The following is a description of a gene set: studied in species Mus musculus The hydrolysis of a peptide bond or bonds within a protein as part of the chemical reactions and pathways resulting in the breakdown of a protein by individual cells. Mouse Gene Set: GOBP_PROTEOLYSIS_INVOLVED_IN_PROTEIN_CATABOLIC_PROCESS, and this is the list of marker genes: Prickle1, Rnf7 (ring finger protein 7), Agap3, Psma1, Syvn1, Kat5, Ube2l3, Fem1b, Rpl23, Ppp2r5c, Zer1, Snf8, Fbxo31, Rmnd5b, Cnot4, Pramel42, Ubxn6, Fbxo10, Herc2, Klhl35, Tdpoz8, Cdc34, Prkcg, Styx, Ubxn2a, Bbs7, Rchy1, Ubr4, Trem2, Chmp1b, Dnajc3, Rnf217, Zranb1, Nhlrc3, Trim25, Pramel48, Psmb9, Psmc2, Fem1a, Cul2 (cullin 2), Trib3, Kctd13, Kcmf1, Psma4, Mapk9, Pramel21, Smarcc1, Znrf3, Sgta, Efna1, Spsb3, Saysd1 (NCBI Gene Id 74979), Siah1a, Dtx3l, Rnf216, Pcbp2, Gna12, Amfr, Pramel22, Smurf1 (SMAD specific E3 ubiquitin protein ligase 1), Arrdc1, Apoe, Pramel40, Kctd21, Ube2r2, Disc1, Acr, Sec61bl, Gipc1, Uchl3, Hectd3, Ctnnb1, Adamts7, Fbxw7, Ctsl, Cul3, Klhl18, Ubr2, Foxred2, Trim67 (tripartite motif-containing 67), Rps27a, Wdr81, Rnf187, Sh3rf2 (NCBI Gene Id 269016), Tbl1xr1, Xbp1 (NCBI Gene Id 52219), Kbtbd2, Pramel13, Klhdc1, Ate1, Klhl2, Otud7a, Fhit, Shh, Hspa5, Eloc, Fap, Kbtbd8, Rffl, Socs4, Psmd3, Ubap1l, Nsfl1c, Isg15, Tor1a, Gzmc, Vhl, Fbxo11, H13, Caml, Klhl3, Cd2ap, Fbxo38, Ccnf (NCBI Gene Id 12449), Rpl11, Park7 (Parkinson disease (autosomal recessive, early onset) 7), Nemf, Nhlrc1, Hdac6, Ube2b, Ctsc, Erlin2, Clec16a, Hace1, Derl2, Rnf34, Sufu (SUFU negative regulator of hedgehog signaling), Rnf123, Zswim8, Ube2srt, Dcaf1, Erlec1, Atg7, Ubxn10, Ubl4a, Rnft2, Rnf168, Usp9x, Ube2c, Psmc5, Ppp1r11, BC051665, Tmem259, Commd1, Pramel28, Tmem67, Pramel47, Taf9, Ark2n, Eif2a, Cts8, Chmp4c, Pramel16, Birc2 (NCBI Gene Id 77616), Rbx1, Kctd10, Nop53, Tsg101, Ddi2, Ube3c, Armc8, Fbxl6, Rnf5, Klhl15, Pramel27, Bcap31, Ube3a, Sharpin, Cdc20b, Ubr5, Trim13 (NCBI Gene Id 66597), Ctsj, Pramel20, Agtpbp1, Asb11, Irgq, Fbxo22, Map3k1, Klhl7, Wnt10b, Akirin2 (NCBI Gene Id 67185), Klhl10, Dnajc10 (DnaJ heat shock protein family (Hsp40) member C10), Ddrgk1, Cpa1, Ubxn4, Gpx1, Spopfm3, Gsk3a, Klhl5, Psmc4, Sel1l, Psmd10, Keap1, Psmb6, Calr3, Oog3, Plg, Mylip, Apc2 (NCBI Gene Id 97679), Amn1, Pramel18, Trim39, Wfs1, Pramel7, Usp5, Gabarap, Siah2, Siah3, Fbxl9, Pramel55, Fem1c, Rnf186, Hspa1b, Zfand2a, Cbfa2t3, Malt1, Ubr3, Umod, Pramel6, Fbxo2, Klhl22, Pcyox1, Tnfaip1, Pramex1, Cacul1, Gan, Cdc20, Tmtc3, Rpl5, Ubqln1, Faf1, Psmb11, Uba1, Ccdc22, Rspry1, Fbxw4, Pramel17, Herc4, Oaz1, Uba1y, Vps4a, Anks1, Chmp2a, Chfr, Arih1, Ctsq, Fbxo48, Dab2ip, Rmnd5a, Kcne2, Pmp22, Ube3d, Ankrd9, Ubxn1, Klhl40, Dmac2, Lonrf2, Rhobtb3, Hamp, Chmp3, Tollip, Ubxn11, Trim38, Ankrd11, Hsp90b1, Canx, Kctd17, Pcyox1l, Oma1, Rnf111, Clpp, Ankib1, Rnf103, Fem1al, Usp19, Fbxo4, Btrc, Psmd2 (proteasome (prosome, macropain) 26S subunit, non-ATPase, 2), Tdpoz9, Mdm2, Fmr1, Rnf125, Psma2, Enc1, Fbxl17, Clock, Dnajb2, Usp13 (NCBI Gene Id 99731), Herc3, Sirt6, Pramel37 (NCBI Gene Id 381724), Klhl4 (NCBI Gene Id 237010), Chmp6, Hecw2, Ecrg4, Fbxo39, Senp1, Rybp, Afg3l2, Dtx4, Hspbp1, Pramel15 (PRAME like 15), Mapk8, Arel1, Psma5, Calr, Pramel36, Psme4, Sirt2, Sirt1 (NCBI Gene Id 93759), Axin2, Ubc, Anapc15-ps, Bmal1, Ambra1, Maea, Rnf26, Trpc4ap, Ddit3 (NCBI Gene Id 13198), Bag2, Rnf166, Psma8, Egf, Ctsz, Kif14, Chmp7, Ddb1, Usp7, Psmc1, Ctsw, Rnf19a, Znrf2, Anapc2, Cdkn2a, Rnf180, Psma6, Ubxn2b, Herc6, Dvl1, Prmt6, Tmem129, Pramel46, Gid8, Man1a (mannosidase 1, alpha), Bag5, Rnf185, Socs7, Mib1, Trib2, Uba7, Rnf144a, Csnk1d, Ube2d3, Pramel30, Clu, Usp14, Ube4b, Ube2j2, Rnf114, Prkn, Proca1, Pkd1, Pramel24, Ttc3, Midn, Derl1, Rnf6, Znrf1, Rnf146, Rpgr, Trim72, Glmn, Stub1 (STIP1 homology and U-Box containing protein 1), Nkd2, Traf4, N4bp1, Ube2u, Rhbdf1, Psme3, Spopfm2, Anapc5, Rnf4, Ascc3, Nedd4, Atp5if1, Sumo2, Edem2, Ube2s, Klhl28, Kbtbd12, Rcn3, Plk1, Ptpn23, Plk3, Cops3, Spsb1, Itch, Epm2a, Anapc11 (NCBI Gene Id 97770), Vps28, Rnf14, Rnf7l, Anapc13, Psmd7, Usp22, Trim32, Tdpoz4 (NCBI Gene Id 677624), Anapc16, Fbxl3, Rbbp6, Pramel45 (NCBI Gene Id 666133), Gzma, Ctso, Dnajb9, Hsp90ab1 (heat shock protein 90 alpha (cytosolic), class B member 1), Rnf145, Klhl29, Pramel31, Ide, Oxa1l, Kctd5, Rps7, Spsb2, Prpf19, Rlim, Hipk2, Trim21 (tripartite motif-containing 21), Kctd6, Pten (NCBI Gene Id 70161), Psma7, Sec61b, Pramel5, Fbxo44, Tmub1, Ddi1, Ctsll3, Brinp1, Ubap1, Zfp598, Wwp1, Fbxl22, Pramel23, Zfand2b, Clpx, Vcp, Spop, Wnt1, Gclc, Gabarapl2, Ctsf, Fbxo6 (NCBI Gene Id 99978), Ubxn7, Ltn1, Chmp2b, Ufl1, Cul1 (NCBI Gene Id 26965), Rnf150, Psmd14, Ttc36, Prkaca, Vps37d, Rnf133, Arrdc4, Fbxo9, Epg5, Psmb1, Klhl20, Ccar2, Lnx1, Ube2g2, Brsk2, Psmb5, Foxf2, Rnf13, Vps37c, Nupr1, Capn2, Cts7, Ptk2, Siah1b, Rybp-ps, Fbxw8, Ube2a, Wwtr1, Plk2, Rnf25, Edem3, Il33, Dcaf13, Rnf10, Ubr1, Trim28, Psmd13, Hfe, Ccdc47, Ube2v2, Lonp1, Nedd4l, Ivns1abp (influenza virus NS1A binding protein), Os9, Ubb, Rnft1, Pcnp, Psen1, Trim63 (NCBI Gene Id 433766), Rnf43, Lats1, Ipp, Psma3, Ufd1, Fzr1, Nccrp1, Gba1, Qrich2, Cdc27, Herpud1, Aurka, Ufsp2, Nr1d1, Nudt15, Rnf121, Psmd11, Psmb7, Cbl, Ube3b, Tmem168, Rc3h2, Eif2ak3 (eukaryotic translation initiation factor 2 alpha kinase 3), Zmpste24, Psen2, Pias1, Mtm1, Pramel43, Psme2, Rnf215, Ube2dnl2, Gid4, Pramel26, Lgmn, Ube2k, Sh3bgrl, Ppp2cb, Tdpoz3, Snhg15, Cav1, Arih2, Uba52, Pramel35, Socs5, Ubqln2, Traf7, Csnk1a1, Psmd6, Fbxo17, Psmd1, Yme1l1, Pml, Lonp2, Hecw1, Usp44, Agbl4, Wdr77, Ctsb, Ptk2b, Ubd, Ecpas, Anapc1, Psmb4, Rack1 (receptor for activated C kinase 1), Klhl41, Ecscr, Usp28, Marchf6, Asb1, Chmp5, Oog2 (oogenesin 2), Ube2d2a, Usp26 (ubiquitin specific peptidase 26), Uchl1, Gsk3b, Trim3, Tbl1x, Csnk2b, Rnf11 (ring finger protein 11), Klhl24, Cts6, Pramel12, Dnaaf4, Cdc26, Pithd1, Ubl7, Sumo3, Vps37b, Dcst1, Rnf213, Rnf167, Fbxo45, Pramel53, Fau, Vps25, Sh3rf1, Socs2, Klhl6, Tmub2, Trim31, Rnf126, Ube2d2b, Klhl17, Uchl4, Tdpoz5, Aup1, Pramel32, Ndfip1, Rnf115, Cts3 (cathepsin 3), Klhl25, Rnf139, Appbp2, Psmf1, Otud5, Pramel1, Kbtbd6, Phf20l1, Anapc15, Pdcd6ip (programmed cell death 6 interacting protein), Klhl8, Psmd4, Klhdc10, Dda1, Psmd8, Rnf170, Ift80, Man1a2, Smurf2, Gm13040, Tgfb1i1, Filip1l, Nfe2l2, Tmem126a, Mtor, Fbxl12, Pramel33, Adamts12, Tdpoz2, Chmp1a, Oog1, Cul9, Hectd1, Psmb10, Nploc4, Hspa1a, Trp53inp2, F8a, Tmx1, Rad23b, Psmc6, Mta1, 4930486L24Rik, Rnf8, Pabpn1l, Bfar, Ube4a, Cdk5rap3, Selenos, Fbxl20, Pramel38, Cdc34b, Cul5, Zyg11b, Arrb2, Fbxw5, Vps37a, Plaa, Faf2, Fbxo7, Ube2w, Calr4, Pramel41, Ube2l6, Kbtbd7, Asb9, Anapc7, Fbxl18, Aqp11, Sumo1, Lrrc75a, Liat1, Ubqln4, Fbxl19, Dtl, Paqr3, Fbxl4, Trim9, Dcaf11, Klhdc3, Dnajb12, Sco1, Pramel29, Styx-ps, Cblc, Klhl23, Marchf7, E330034G19Rik (NCBI Gene Id 620651), Usp38, Ube2h, Ogt, Ctsm, Ascc2, Rad23a, Klhl30, Klhl12 (kelch-like 12), Tlk2, Trim45, Pramel60, Rhbdd1, Pbk, Jkamp, Psmb2, Fbxo3 (F-box protein 3), Map1a, Dlgap1, Spopl (NCBI Gene Id 99466), Cul7, Alad, Pmaip1, Skp1, Vps4b, Csnk1e, Ankzf1, Peli1, Rnf40, Trf, Fbxo8, Ube2z, Bag6, Man1b1, Ubqln5, Klhl21, Afg2b, Bap1, Klhl11, Pramel14, Vps36, Laptm5, Ubqln3, Rnf19b, Desi1, Pramel19, Osbpl7, Nrros, Ctss, Afg1l, Mkrn2, Fbxl5, Rnf20, Uchl5, Dcaf12, Znrf4, Wwp2, Sdf2l1, Psme3ip1, Ube2d1, Rgn, Lamp3, Ube2n, Chmp1b2 (NCBI Gene Id 74520), Trim58 (tripartite motif-containing 58), Axin1, Tnfaip3, Derl3, Nfe2l1, Wac, Erlin1, Asb2, Gzmn, Topors, Psmb8, Cul4b, Trip4, Rbx1-ps, Ube2g1, Csnk2a2, L3mbtl3, Uhrf1, Ube2j1, Tdpoz1, Rnf149, Spsb4, Xpo1, Pramel51, Rnf130, Nub1, Ndfip2 (NCBI Gene Id 77152), Ern1, Cdc16, Araf, Fbxl15, Trim2, Pramel25, Ercc8, Tmf1, Uba6, Ctsk, Epha4, Psme1, Anapc4, Naglu, Kbtbd3, Rnf122, Ubqlnl, Klhdc2, Trib1, Psmb3, Rc3h1, Atxn3, Huwe1, Skp2, Pja2, Chmp4b, Ntan1, Cdc23, Casp8, Pramel11, Get4, Fbxl13, Svip, Trip12, Yod1, Wdr26, Rnf41, Fbxl2, Stam, Eif3h, Pabir1, Pramel44, Akt1, Lrrk2, Sel1l2, Arrb1, Dab2, Rnf144b, Fbxo27, Crbn, Psmc3, Usp25, Cop1, Rnf26rt, Rnf128, Fbxw11, Edem1, Klhl42, Nedd8, Man1c1, Ubac2, Clgn, Ube2dnl1, Egfr, Fbxl7, Rbck1, Sh3rf3, Kctd2, Otud7b, Det1, Oog4, Ctsh, Zfp418, Apc (NCBI Gene Id 11789), Gzmb, Klhl38, Ophn1, Fbxl16, Stt3b, Trim26, Tbx21, Rnf148, Cul4a, Anapc10 (NCBI Gene Id 68999), Trim71, Socs6, Pdcl3 (phosducin-like 3), Ccin, Fbxl14, Ctsr, Klhl1, Ubxn8